Given this list of marker genes PMS2P12, SPDYE2B, PUS7, UPK3BL2, ARPC1A, KPNA7, SERPINE1, COL26A1, MUC12, MBLAC1, PMPCB, KMT2E, VGF, DUS4L, SLC12A9-AS1, PVRIG (PVR related immunoglobulin domain containing), PIK3CG, ALKBH4, PDAP1, KMT2E-AS1, GPR22, TRIP6, POLR2J2, PRKAR2B, YBX1P2, COPS6, DGAT2L7P, UFSP1, CYP3A7-CYP3A51P, NYAP1, SH2B2, FBXO24, MEPCE, ZNF3, MIR4285, POP7, SYPL1, RPL36P12, POLR2J3, ACHE, TAF6, RN7SL416P, NAPEPLD, MIR5090, AZGP1 (alpha-2-glycoprotein 1, zinc-binding), MIR4658, NAT16, NFE4, PCOLCE, NAMPT-AS1, SLC26A4-AS1, RPSAP46, RASA4DP, MUC17, ZKSCAN5, PVRIG2P, SPDYE2, RPS29P15, TFR2, RASA4 (NCBI Gene Id 10156), MIR93, STAG3, ZNF394, MYH16, AGFG2, CLDN15, TRRAP, CBLL1, RELN, NAMPT, BAIAP2L1, PSMC2, ATXN7L1, RWDD4P1, ZKSCAN1, LHFPL3, LINC01007, LINC02577, RPL23AP95, GPC2, SLC26A4, TMEM225B, PRKRIP1, CBLL1-AS1, CDHR3, POLR2J2-UPK3BL1, LAMTOR4, OR2AE1, RPL7P60, RNA5SP236, DPY19L2P2 (NCBI Gene Id 653912), RN7SL8P, ZNF789, GJC3, DUS4L-BCAP29, CYP3A5, ZAN, CPSF4, TMEM130, SAP25, RNF14P3, ARMC10, ZNF655, RN7SKP198, EIF4BP6, S100A11P1, COG5, ORAI2, RNU6-1322P, MCM7, ZNHIT1, RN7SL549P, MIR4653, TRIM56, ENSG00000286013, BANF1P5, LRCH4, PILRA, RPL7AP39, MIR6875, EFCAB10, DNAJC2, RN7SL750P, WBP1LP2, CNPY4, CTB-30L5.1, MIR548O, CYP3A51P, CYP3A7, MYL10, MOGAT3, AP1S1, CRYZP1, ZCWPW1, SLC26A5, UPK3BL1, ZSCAN25, ATP5MF-PTCD1, MIR106B, ORC5, PLOD3, TRIM4, PPP1R35, TRAPPC14, LNCPRESS1, MUC3A, RNU6-392P, MIR25, RN7SKP86, DCAF13P1, STAG3L5P-PVRIG2P-PILRB, CYP3A4, EPO, RNU6-393P, SPDYE6, PPIAP82, AZGP1P1, AP4M1, PILRB, RINT1, ACTL6B, POLR2J, ZSCAN21, MIR3609, FBXL13, MUC12-AS1, MIR6840, SLC26A5-AS1, FIS1, IRS3P, SMURF1, NPTX2, CCDC71L, ENSG00000286923, CYP3A52P, TSC22D4, AZGP1P2, CUX1, RASA4B, STAG3L5P, PCOLCE-AS1, HBP1, PMS2P1, CYP3A137P, LRRC17, EPHB4, EFCAB10-AS1, GIGYF1, GAL3ST4, ARPC1B, IFT22, BCAP29, RPS29P16, EMSLR, RN7SKP54, SRRT, PTCD1, SPDYE3, SPACDR, LHFPL3-AS1, FAM185A, RNU6-1104P, RPL13AP16, CASTOR3P, PPP1R35-AS1, MOSPD3, SLC12A9, CYP3A43, SRPK2, BUD31, LRWD1, GNB2, ENSG00000222966, LARP1BP2, PRKAR2B-AS1, ENSG00000284523, RNU6-1136P, MIR4467, ATP5MF, FAM200A, here is a description of the gene set: Human Gene Set: chr7q22 studied in species Homo sapiens